The following is a description of a gene set: A component of the transcription machinery of RNA Polymerase II. In humans, TFIIA is a heterotrimer composed of an alpha (P35), beta (P19) and gamma subunits (P12). Mouse Gene Set: GOCC_TRANSCRIPTION_FACTOR_TFIIA_COMPLEX studied in species Mus musculus, and this is the list of marker genes: Tbpl1, Gtf2a1l, Gtf2a1, Gtf2a2, Tbp